Given this list of marker genes Rpp14, Elac2, Tsen2, Tsen34, Rpp30, Prorp, Pop1, Pop5, Rpp25, Elac1, Rpp40 (ribonuclease P 40 subunit), Rpp38, Pop7, Ang, Pop4, Rpp21, here is a description of the gene set: studied in species Mus musculus Catalysis of the hydrolysis of phosphodiester bonds in tRNA molecules. Mouse Gene Set: GOMF_TRNA_SPECIFIC_RIBONUCLEASE_ACTIVITY